The following is a description of a gene set: Human Gene Set: GOMF_BETA_GLUCOSIDASE_ACTIVITY Catalysis of the hydrolysis of terminal, non-reducing beta-D-glucose residues with release of beta-D-glucose. studied in species Homo sapiens, and this is the list of marker genes: KL, GBA3, GBA1, GBA2, LCT